Given this list of marker genes LZTFL1, TRIM32, MC4R, BBS7, BBS2, POMC, BBS9, NPHP1, IFT172, PCSK1, ARL6, CEP19, CFAP418, BBIP1, SCAPER, MKS1, TTC8 (NCBI Gene Id 123016), CEP290 (centrosomal protein 290), SCLT1, IFT27 (intraflagellar transport 27), WDPCP, IFT74, BBS4, VPS13B, BBS1, MKKS, BBS10, INPP5E, BBS5, SDCCAG8, BBS12, here is a description of the gene set: Human Gene Set: HP_CHILDHOOD_ONSET_TRUNCAL_OBESITY studied in species Homo sapiens Truncal obesity with onset during childhood, defined as between 2 and 10 years of age. Childhood-onset truncal obesity